Given this list of marker genes Pemt, Bloc1s6, Nt5c2, Ak1, Xdh, Uox, Dctd, Nt5c1a, Ahcy, Acp3, Ada, Upp2, Aprt, Urad, Adk, Pnp, Mtap, Pcmt1, Cda, Icmt, Upp1, Adal (NCBI Gene Id 75894), Hprt1, Nt5c1b, Pgm2, Urah, Pnp2, Ahcyl, Aicda, Ptgdr, Pycr3, Nt5c3 (5'-nucleotidase, cytosolic III), Cdadc1, Nt5e, Gamt, Enpp4, Gnmt, here is a description of the gene set: studied in species Mus musculus Mouse Gene Set: GOBP_RIBONUCLEOSIDE_METABOLIC_PROCESS The chemical reactions and pathways involving any ribonucleoside, a nucleoside in which purine or pyrimidine base is linked to a ribose (beta-D-ribofuranose) molecule.